The following is a description of a gene set: studied in species Mus musculus Mouse Gene Set: GOMF_G_PROTEIN_COUPLED_NEUROTRANSMITTER_RECEPTOR_ACTIVITY Combining with a neurotransmitter and transmitting the signal across the membrane by activating an associated G-protein; promotes the exchange of GDP for GTP on the alpha subunit of a heterotrimeric G-protein complex., and this is the list of marker genes: Gpr158, Gabbr1, Kctd12, Chrm2, Grm1, Chrm4, Kctd12b, Chrm5, Kctd8, Kctd16, Chrm1 (cholinergic receptor, muscarinic 1, CNS), Adrb1, Gabrb1, Chrm3